Given this list of marker genes PON2, ALOX5AP, GPX2, ALOX5, PON1, GPX4, LTC4S, GPX1, PON3, here is a description of the gene set: studied in species Homo sapiens Synthesis of 5-eicosatetraenoic acids Human Gene Set: REACTOME_SYNTHESIS_OF_5_EICOSATETRAENOIC_ACIDS